Given this list of marker genes Ifih1, Nfe2, Bloc1s1, Cbx4 (NCBI Gene Id 12418), Senp2, Mettl21c, Dip2a, Sirt1, Setd2, Pcbp1, Ep300, Ndufab1, Semp2l1, Eya1, Fscb, Rela, Rasd2, Sirt3, Cth, Zmiz1, Park7, Etfbkmt, Egr1, Esco1, Dohh, Dhps, Nat8f1, Egr2, Hdac6, Smo, Sumo3, Plod2, Tollip, Loxl3, Nat8, Semp2l2a, Uspl1, Traf7, P3h3, Senp1, Dip2b, Vcpkmt, Kat7, Atpsckmt, Eef2kmt, Vipas39, Ranbp2 (RAN binding protein 2), Hint1, Bcl11a, Smyd2, Gnl3l, Setd6, Sumo2, Vps33b, Lox, Lias, Zmiz2, Eef1akmt2, Jmjd6, Loxl2, Sirt4, Pias4, P3h4, Ehmt2, Atat1, Fkbp10, Pias1, Hint2, Eef1akmt3, Plod1, Kmt2a, Smc5, Senp5, Capn3, Setd7, Hdac2, Mul1, Rnf212, Uba2, Zfp451, Semp2l2b, Senp7, Stx1a, Pml, Trpm4, Gcsh (NCBI Gene Id 68413), Rangap1, Trim38, Antkmt, Pias3, Ahrr, Prkaa1, Bag6, Cdkn2a, Nat8f7, Mettl18, Pcbp2, Ube2i, Wdr5, Bola3, Senp6, Kat2a, Atp7a, Kif3a, Hmg20b, Ctnnb1, Camkmt, Sumo1, Kat2b, Pias2, Shh, Plod3, Nat8b-ps, Senp3 (NCBI Gene Id 80886), Hmg20a, Sae1, Klf15, Gnl3, Lipt2, Arnt, Rwdd3, Kat5, Sirt5, Ndufab1-ps, Hdac4, Sirt2, Fn3k, Lipt1, Kmt5a, Desi1, Nsmce2, Hdac9, Sox4, Fn3krp, Trim28, Topors, Mettl21a, Ehmt1, Eef1akmt1, Crebbp, Prkaa2, here is a description of the gene set: The modification of peptidyl-lysine. Mouse Gene Set: GOBP_PEPTIDYL_LYSINE_MODIFICATION studied in species Mus musculus